Given this list of marker genes CHRNB4, CHRNA6, CHRNB3, CHRNA1, CHRNA5, CHRNA4, CHRNA3, CHRNB2, CHRNA2, here is a description of the gene set: Human Gene Set: REACTOME_HIGHLY_CALCIUM_PERMEABLE_NICOTINIC_ACETYLCHOLINE_RECEPTORS studied in species Homo sapiens Highly calcium permeable nicotinic acetylcholine receptors